Given this list of marker genes WDFY3, RUNX1T1, WBP1L, MSI1, GNG7, ZNF154, EPB41, TLX1, GPCPD1, PCDH9, TIFA, SPRY3, TCHH, RBPJ, OPRM1, DELE1, TNKS2, ZNF586, SGPP1, XPNPEP1, GAL3ST3, EDEM3, ATP6V1G2, SANBR, TNFAIP2, C1orf52, GRB14, S100A7A (NCBI Gene Id 338324), APC, PREX1, FAM131B, ZCCHC2, EGR3, MAML2, OGT, MICAL3, SMARCD1, PTPRA, MGA, CACNB3, SHANK2, MDGA2, NALF1 (NALCN channel auxiliary factor 1), MR1, VIT, OAS1, KDM7A, RSF1, FOXG1, LSMEM2, ACVR2B, SLIT3, ARNT, PDS5B, TSC22D1 (TSC22 domain family member 1), PDLIM4, PCBP1, MAPK9, NANOS1, TMEM94, here is a description of the gene set: studied in species Homo sapiens Human Gene Set: MIR619_3P from publication Chen Y, Wang X (PMID 31504780) Genes predicted to be targets of miRBase v22 microRNA hsa-miR-619-3p in miRDB v6.0 with MirTarget v4 prediction scores > 80 (high confidence targets).